Given this list of marker genes ZNF185, TRIOBP, SDC4, CCN3, C1QL2, VENTX, GAD1, AJAP1, SIGIRR, PTPRN, UBE2C, ZHX3, IL13RA2, SNTB1, C1orf94, CARD16, ZDHHC14, P3H2, SPINK1, VCX3A, MANEAL, SHTN1, RGS17, VWA5A, FLRT2, HELZ2, MT2A (metallothionein 2A), PIK3R1, EHD1, NMRAL1, RTN1, MAF, PGM2L1, PLXDC2, AGA, here is a description of the gene set: Genes down-regulated in HT1080 cells (fibrosarcoma) over-expressing MMP14 compared to those with knockdown of the gene by RNAi. studied in species Homo sapiens from publication Rozanov DV, Savinov AY, Williams R, Liu K, Golubkov VS, Krajewski S, Strongin AY (PMID 18519667) Invasion-promoting MT1-MMP is directly linked to tumorigenesis and metastasis. Our studies led us to identify those genes, the expression of which is universally linked to MT1-MMP in multiple tumor types. Genome-wide expression profiling of MT1-MMP-overexpressing versus MT1-MMP-silenced cancer cells and a further data mining analysis of the preexisting expression database of 190 human tumors of 14 cancer types led us to identify genes, the expression of which correlated firmly and universally with that of MT1-MMP (P < 0.00001). These genes included regulators of energy metabolism (NNT), trafficking and membrane fusion (SLCO2A1 and ANXA7), signaling and transcription (NR3C1, JAG1, PI3K delta, and CK2 alpha), chromatin rearrangement (SMARCA1), cell division (STK38/NDR1), apoptosis (DAPK1), and mRNA splicing (SNRPB2). Our subsequent extensive analysis of cultured cells, tumor xenografts, and cancer patient biopsies supported our data mining. Our results suggest that transcriptional reprogramming of the specific downstream genes, which themselves are associated with tumorigenesis, represents a distinctive molecular signature of the proteolytically active MT1-MMP. We suggest that the transactivation activity of MT1-MMP contributes to the promigratory cell phenotype, which is induced by this tumorigenic proteinase. The activated downstream gene network then begins functioning in unison with MT1-MMP to rework the signaling, transport, cell division, energy metabolism, and other critical cell functions and to commit the cell to migration, invasion, and, consequently, tumorigenesis. Human Gene Set: ROZANOV_MMP14_TARGETS_DN